Given this list of marker genes RHOH, PAK2 (p21 (RAC1) activated kinase 2), WDR11, PAK1, UACA, VANGL1, RALGAPA1, CAV1, OSBPL11, CSK, ARHGDIA (NCBI Gene Id 396), TMEM59 (NCBI Gene Id 9528), RAB7A, VAMP3, NIPSNAP2, FAM91A1, PAK6, LAMTOR1, DBT, PAK5, LCK, SLC4A7, DBN1, VCP, ROCK1, NSFL1C, STOM, TUBA1B, MTR, TFRC, PAK4, ROCK2, JUP, SLC1A5, ARHGDIG, ZAP70, ARHGDIB, here is a description of the gene set: Human Gene Set: REACTOME_RHOH_GTPASE_CYCLE RHOH GTPase cycle species: Homo sapiens